Given this list of marker genes Cnot3, Cnot8, Cnot9, Cnot1, Cnot7, Cnot2, here is a description of the gene set: The core of the CCR4-NOT complex. In Saccharomyces the CCR4-NOT core complex comprises Ccr4p, Caf1p, Caf40p, Caf130p, Not1p, Not2p, Not3p, Not4p, and Not5p. Mouse Gene Set: GOCC_CCR4_NOT_CORE_COMPLEX studied in species Mus musculus